The following is a description of a gene set: Human Gene Set: GSE17721_CTRL_VS_POLYIC_24H_BMDC_DN Genes down-regulated in comparison of control dendritic cells (DC) at 24 h versus those stimulated with poly(I:C) (TLR3 agonist) at 24 h. species: Homo sapiens mouse primary BMDCs were stimulated with tlr ligands and gene expression changes were profiled on Affymetrix arrays from publication Amit I, Garber M, Chevrier N, Leite AP, Donner Y, Eisenhaure T, Guttman M, Grenier JK, Li W, Zuk O, Schubert LA, Birditt B, Shay T, Goren A, Zhang X, Smith Z, Deering R, McDonald RC, Cabili M, Bernstein BE, Rinn JL, Meissner A, Root DE, Hacohen N, Regev A (PMID 19729616), and this is the list of marker genes: ARF4, CCL1 (NCBI Gene Id 6346), ZSCAN22, POU3F3, CD83, CD82, SAP30, AP1G2, MIOX, TM2D3, MBD6, VTN, KLRK1, NUP88, PTGES, CD47, GCH1, FABP7, TNF, ZNHIT2 (zinc finger HIT-type containing 2), MC1R, PPP1R15A, TGM2, STARD3, TTC39C, EFNA4, JAK2, IFT57, UGP2, PRDX1, PPDPF (pancreatic progenitor cell differentiation and proliferation factor), DNAJB1, LCT, ZEB1, NR5A2, DCAKD, RIPK2, CDH1, DDIT3, NEU3, RBP7, TSPAN33, VAMP8, GK2, SLC39A1, SLC29A3, TPBG, CCDC71L, COL4A3, RNH1, RAD51B, ALPK2 (NCBI Gene Id 115701), CAV1, LIPF, PSME3, PAWR, ARFRP1, SLC28A2, ELAPOR1, BLOC1S4, COPS5, DLGAP4, MDFIC, HNRNPD, AIG1, CHD1 (chromodomain helicase DNA binding protein 1), MYORG, PIP5KL1, TMEM131, RAD23A (NCBI Gene Id 5886), G3BP2, PDLIM4, PSMC2, SPAG7, NUDT3, GRB2, BST2, TSPAN13, CLDN14, GTF2IRD2, CST3 (NCBI Gene Id 1471), FGF7, POLB, PML, PLEKHG2, C1orf52, CEP350, CCNT1, TAB2, SDHAF1, CCL5, PSMA4 (proteasome 20S subunit alpha 4, NCBI Gene Id 5685), TRIM41, FBXW11, TIMP1, INHBA, MMP17, PLIN3, M1AP (NCBI Gene Id 130951), HTR2B, FGL2, KRT18, DDX4, PTX3, KIN, ACTN1, SPEN, ATAD2B, BLOC1S6, MTMR7, USP25, HK2, RNF149, BASP1, JAG2, RLN1, APOBEC2, LAP3, RNF214, SPTLC2, EMC7, ELOF1, ABR, FER, FRRS1 (ferric chelate reductase 1), ZNG1B, ZC3H18, SLFN12L, TEK, ADGRG1, WASHC4, KEAP1, NUB1, AGFG1, GSDME, ANXA5, NCOR1, TIMM50, KRTCAP2, TENT2, SLAMF8, ESD, RANBP1, BCL2L14, TGFA, PSME3IP1, KLHL22 (NCBI Gene Id 84861), MTMR14, SECISBP2, GNG11, GTPBP1, ERGIC2, NFKBIA, LARP4B, SFT2D2, TM4SF4, LMO4, CMTR1, HSD17B13, KCNH7, STXBP1, LHX2, MSLN, PTPN6, NUPR1, RBM47, CX3CL1, KYAT3, MYOG, RBM42, DPCD, KTN1, CUEDC1, CAMK2D, GDF15, SPRR2F, RNF208, SMOC1, GCLC, CWH43, SPRTN, CSPG4, MX2, RGL1, GDE1, IL6ST, BHLHE41, RABL6, CD209, N4BP1, DCTN4, CCT7, DDA1, MECP2, PDK3, MAGI2, AGR3 (NCBI Gene Id 155465), HPS4, KCNA6, BFAR